The following is a description of a gene set: species: Homo sapiens A focal-onset seizure is a type of seizure originating within networks limited to one hemisphere. They may be discretely localized or more widely distributed, and may originate in subcortical structures. Focal-onset seizure Human Gene Set: HP_FOCAL_ONSET_SEIZURE, and this is the list of marker genes: EIF4A2, TRIM8, GABRG2, GABRB3, KCNT1, CLN8, COL4A1, MT-TQ, PIGQ, AKT1, MYT1L, NDUFA2, SDHAF1, NF2, PPIL1, TREX1, GABBR2, MT-TH, MTOR, AMACR, SLC38A3 (NCBI Gene Id 10991), SMC1A, SLC31A1, MT-ND6, DEPDC5, NF1, SLC6A1, CDC40, GALNT2, SUFU, CRIPT, CYP26C1, PIK3CA, PNKP, IER3IP1, NPRL2, SCN3A, KCNB1, AFG2B (NCBI Gene Id 80051), TBC1D24, EHMT1, MTFMT, CUX2, DMXL2, TGFB1, VAMP2, TFE3, NARS1, AP3D1, TRAF3, PTPN23, BRAT1, ADGRV1, BAP1, CACNA1C, TICAM1, ATXN10, WARS2, SLC12A5, COX11, UNC93B1, FBXO28, HCN1, EPM2A, CLN6, MT-CO3, METTL23, GRIN2B, SLC2A1, GNB1, CTSF, NUS1, GRIN2A, ACBD6, SDHA, GOSR2, KANSL1, CLCN4, KCNA1, VPS35L, NECAP1, DNM1L, ROGDI, CNOT1, PACS1, CASR, DPYD, SRPX2, MTHFR, KCNC2, CAPRIN1, RPL10, NACC1, SNORD118, ARX, MDH2, GAL, VARS2, PPP3CA, CNTN2, NPRL3, CABP4, ATP6V1A, ITPR1, CARS2, CTNND2, SAMD12, STXBP1, HACE1, LRP5, RELN, TLR3, HID1, ACSF3 (NCBI Gene Id 197322), ADGRG1, FIG4, CLCNKB, STX1B, NFU1, PDE2A, ARF1, PLPBP, SLC1A3, DCX, POLG, SCN8A, TANGO2, KDM6A, ERMARD, CHRNA2, MTHFS, CNPY3, SEC31A, MACF1, ATP6V0A1, RNH1, SDHD, CIC, NSD1, CDKL5, PSAP (prosaposin), MRAP, SLC32A1, NEUROD2, FLNA, GRIA3, GAMT, DPYSL5, PLCB1, ACO2, NBEA, MT-ND1, ADRA2B, KCNK4, NEDD4L, ATP1A3, AHDC1, DYNC1H1, MT-TF, UFSP2, HTT, GRM7, MT-ND4, SCN9A, SMO, YWHAG (tyrosine 3-monooxygenase/tryptophan 5-monooxygenase activation protein gamma), PPOX, ALDH7A1, MBOAT7, NCDN, PDGFB, SYNGAP1, TSC2, SDHB, VARS1, GNAI1, BTD (NCBI Gene Id 92108), GLYCTK (glycerate kinase), GRIN1, AP2M1, COL4A2, SZT2, MARCHF6, FGFR3, POLRMT, TUBB2B, ATP6V1B2, CNTNAP2, MICAL1, SIK1, PIGW, SPTAN1, CHD2, PYCR2 (pyrroline-5-carboxylate reductase 2), POGZ, APC2 (APC regulator of WNT signaling pathway 2), FGF12, PRRT2, PAFAH1B1, GOLGA2, KCNMA1, WDR45B, DOCK7, SLC25A22, ARHGEF9, KCNQ2, MT-ND5, GABRA5, POU4F1, PPP2R5D, SCN2A, BCKDK, CHRNB2, MT-TS2, PURA, GABRA3, CRELD1, HHAT, ADAM22, GABRD, MT-CO2, SATB1, ST3GAL3, RARS1, KCNQ3, MT-TW, IFNG, PPP2CA (protein phosphatase 2 catalytic subunit alpha), AFF3, TMEM94, PHGDH, CLCN3, SLC35A3, PEX3 (NCBI Gene Id 8504), ZEB2, TERT, COPB1, TSC1, KCTD7, SPTBN1, FBXL4, YEATS2, KCNQ5, CDH2, EXOC7 (exocyst complex component 7), PACS2, PCYT2 (phosphate cytidylyltransferase 2, ethanolamine), PIGS, PNPLA8, AGO1, FOXG1, CPLX1, CASK, OPHN1, EN1, PI4KA, LGI1, ARV1, GRIA2 (glutamate ionotropic receptor AMPA type subunit 2), FGF13, CACNA1D, NHLRC1, WWOX (NCBI Gene Id 9621), PRMT7, PUS3, COQ4, ZNFX1, FRRS1L, ADPRS, SCN1B, PIGA, CRH, ATP5PO, TMTC3, KMT2D, ATP6V0C, SMARCAL1, H4C5, FBP2, MAST3, RNU12, MAP1B, PIGP, MT-TL1, GLI3, NDUFAF6, VPS11, CHRNA4, KCNH5, SLC25A10, PCDH12 (NCBI Gene Id 51294), AP4S1, SMARCB1 (SWI/SNF related, matrix associated, actin dependent regulator of chromatin, subfamily b, member 1), FAR1, SYN1, TBK1, FA2H, TUBA1A, ESAM, DOLK, DPAGT1, FZR1, ADA2, POLR3A, LAMA2, NEXMIF, OTUD7A, DNM1, EXTL3, MAPK10, PDSS2, SMS, CEP85L (NCBI Gene Id 387119), ARFGEF2, SLC12A3, CAMK2B, SLC22A5, MT-CO1, TRAF7, TUBB3, CSF1R, SLC1A2, STRADA, LAMC3, GABRA1, RERE, SCN1A, GRIK2, GNB2, GLUL, SLC13A5, AKT3, CPA6, NR4A2, CAMTA1, SUPT16H, SMARCE1, KCNJ11, GJC2, PCDH19, PPFIBP1, LGI4, GCSH, FMN2, KDM6B, ATP1A2, CACNA1A, TBCK, NGLY1, CACNA2D1, GNAO1